The following is a description of a gene set: The mitogen-activated protein kinases (MAPKs) are a family of serine/threonine kinases that play an essential role in signal transduction by modulating gene transcription in the nucleus in response to changes in the cellular environment. They include the extracellular signal-regulated protein kinases (ERK1 and ERK2); c-Jun N-terminal kinases (JNK1, JNK2, JNK3); p38s (p38alpha, p38beta, p38gamma, p38delta) and ERK5. The molecular events in which MAPKs function can be separated in discrete and yet interrelated steps: activation of the MAPK by their upstream kinases, changes in the subcellular localization of MAPKs, and recognition, binding and phosphorylation of MAPK downstream targets. The resulting pattern of gene expression will ultimately depend on the integration of the combinatorial signals provided by the temporal activation of each group of MAPKs. This review will focus on how the specificity of signal transmission by MAPKs is achieved by scaffolding molecules and by the presence of structural motifs in MAPKs that are dynamically regulated by phosphorylation and protein-protein interactions. We discuss also how MAPKs recognize and phosphorylate their target nuclear proteins, including transcription factors, co-activators and repressors and chromatin-remodeling molecules, thereby affecting an intricate balance of nuclear regulatory molecules that ultimately control gene expression in response to environmental cues. Human Gene Set: TURJANSKI_MAPK11_TARGETS from publication Turjanski AG, Vaqué JP, Gutkind JS (PMID 17496919) Examples of transcription factors whose activities are regulated by MAPK11 phosphorylation. species: Homo sapiens, and this is the list of marker genes: ATF2, ELK1, MEF2A, FOS, MEF2C